The following is a description of a gene set: species: Homo sapiens Genes up-regulated in epithelial cells (6h): untreated versus interferon alpha. from publication Sanda C, Weitzel P, Tsukahara T, Schaley J, Edenberg HJ, Stephens MA, McClintick JN, Blatt LM, Li L, Brodsky L, Taylor MW (PMID 16800785) Type I and type II interferons (IFNs) bind to different cell surface receptors but activate overlapping signal transduction pathways. We examined the effects of a type I IFN (IFN-acon1) and a type II iFN (IFN-g1b) on gene experession in A549 cells and demonstrate that there is a common set of genes modulated by both IFNs as well as a set of gene specifically regulated by each, reflecting the activation of different signaling pathways. In particualr, IFN-g induced many more genes of the signaling pathways, apoptosis, and cytokine interactions than did IFN-a. Even with genes induced by both IFNs there were distinctive quantitativive differences in expression. IFN-g1b plays a major role in the induction and regulation of the complement pathway. Previous work has shown a synergistic antivral and antiproliferative effect of type I and type II IFNs in cell culture and in the treament of tumors in mice. We demonstrate that a majority of genes showed and additive effect of IFN-acon1 and IFN-g1b, but a subset of gene is synergistically induced; these incluce ISG10, MX2, OAS2, and other genes known to be involved in the antiviral response, TRAIL (TNFSF10) and caspases involved in apoptosis and chemokine genes RANTES, CXCL10, and CXCL11. Greater than additive transcription of some of these genes in the presence of both IFNs was confirmed by real-time kinetic RT-PCR. Elevated induction of many of these genes may be sufficient to explain the synergistic antiviral and antitumor effects of this combination of IFNS in vivo. Human Gene Set: GSE5542_UNTREATED_VS_IFNA_TREATED_EPITHELIAL_CELLS_6H_UP, and this is the list of marker genes: SEC24C, ERN1, CLDND1, RNF135, TLR6, SSTR5-AS1, NIBAN1, CYSLTR1, TGFB1, RBBP8 (RB binding protein 8, endonuclease), OR7A2P, PYHIN1, NSD3, ROCK1P1, BMPR1A, IQGAP1, MIR96, CD99, MIR21, ATP6V1B2, THSD1, HBB, GIPR, EIF3A, LGALS9, UST, NCOA7, RHBDF2, ALCAM, DNAJC22, HNRNPUL1, CMIP, SLC7A11, SEC14L1, ATN1, CAPN1, CD58, ERICH3, RDH10, LUZP1, EPHA4, ODF2, HAVCR2, CHST11, SURF4, NFATC2, FAM50A, HEATR9, TSEN54, PPARA, SYN2, RHOJ, MVD, RUNX3, ACOT9, CST7, PIEZO1, SYT16, NFATC1, CLIC1, CPOX, SH3BGRL3, AHNAK, LRRC9, RUBCN, DKK3, TMPRSS7, GPRIN3, ATP2B4 (ATPase plasma membrane Ca2+ transporting 4), RYR2, NECAB3, GABARAPL1, ANXA2, PKHD1, F2R, PI4K2A, NPC1, ZFYVE1, CXCR3, SP140, PHACTR2, ANXA4, APOBEC3F, MERTK, NAV3, MAP3K1, KRTAP12-2, KLRD1, STAT5B, MARK2P21, CGAS, PTGDR, MEF2C, GZMK, ENTPD1, SHKBP1 (NCBI Gene Id 92799), LPIN2, FYN, ST8SIA1, USP46, ADK, PPP2R5C, SLC6A15, PAK3, PCBD1, IGSF9B, DUSP10, ORAI2, CRIM1, MYO9B, HIP1, SHMT2, GALM, CD1A, PRDM1, LYAR, ATXN1, EFHD2, NBEAL2, IRF4, PHF12, SH2B3, EOMES, TIGIT, ZBTB49, FMO5, NEK6 (NIMA related kinase 6), RNF166 (ring finger protein 166), F5, LYPD6B, COTL1, SUSD6, MIR365A, ZC3H12C, TLN1, TLR10, SH2D2A, BPIFA4P, OGDH, ILRUN, MBOAT1 (NCBI Gene Id 154141), TRANK1, CDC14A, OR6K2, RIPK3, ITGB1, ARAP2, STOM, TPTE2P6, TEPSIN, C1orf21, FCRL2, SESN3, GATA3 (GATA binding protein 3), FAS, ARFGAP3, ACTN4, IGSF10, SLAMF1, MIR24-2, FTH1, GLB1L3, IL2RB, SLC4A11, EPHA3, LRP8, LINC00683, CACNB1, NABP1, MYO1F (NCBI Gene Id 4542), FLOT1, SYT11, GBP4, IL18RAP, MYBL1, OR1C1, TGFBR3, ARID5B, LLGL2, LRIG1, SMC4, TTYH2, ARL6IP1, NXPE1, ZEB2, TBX21, JOSD1, LINC02880, KDM5C, SLC37A1, GPR141, ETV6, ARF3, GNB1, SLC28A3, GPR183, MAST2, TNIP3, MAP3K12, TANK